The following is a description of a gene set: species: Mus musculus Mouse Gene Set: GOBP_BUD_ELONGATION_INVOLVED_IN_LUNG_BRANCHING The process in which a bud in the lung grows out from the point where it is formed., and this is the list of marker genes: Spry2, Spry1, Fgf10, Yap1 (NCBI Gene Id 22601), Rdh10, Fgfr2, Bmp4